Given this list of marker genes Hspa9, Leprotl1, Rbpj, Nkd1, Gm6878, Grm7, Nbl1, Krtap6-6, Gxylt1, Fermt1, Gid4, Ntng1 (netrin G1), Frat1, Zfp790, Hrh2 (histamine receptor H2), Kif3c, 1700028K03Rik, Taok1, Coq8b, Nr2c2, Trim46, Ezh2, Mapkbp1, Impdh1, Elk4, Tmem266, Natd1, Hmbox1, Atg13, Coro7, Ppm1l, Rb1, Smyd5, Cep350, Zdhhc20, Slc9a9, Dpy19l3, Celf4, Nfat5 (nuclear factor of activated T cells 5), Bltp3a, Gm16130, Camta1, Psma1, Srp14, Msantd3 (Myb/SANT-like DNA-binding domain containing 3), Pcnx2, Pgam1, Ephb2, Gbx2, Tmem178b, Kmt2a, Hs3st3a1, Mtif3, Itga5, Acot3, Ppargc1a, Esr1, Fam78a, Cavin1, Shisal2b, Zfp788, Snx27, Smg1, Sppl2b, Zeb2, Macrod2 (mono-ADP ribosylhydrolase 2), Slc8a2, Wdr47, Kpna3, Cuedc1, Cplx3, Bcl9, Anks1, Gabrg2, Ppp1r12a, Garem1, Zbtb14, Cnot6, Pgrmc2, Bicd2, Tmod1, Larp4b, Gpatch2l, Kcnq5, Cnga4, Acvr2b, Thtpa, Kmt2c, Nfya, Hipk3, Elovl5, Ubiad1, Fbxo11, Kcna6, Tbc1d16, Fat3, Fhip2b, Prx, Gab2, Erc1, Ubqln3 (ubiquilin 3), Tbl1xr1, Nexmif, Csde1, Mtf2, Cd22, Ctsb, Pacrg, Sox5, Gtpbp2, Zc3h6, Arhgef12, Slc39a12, Smurf2, Nup160, Qsox2, Csf1, Olfm1, Usp36, Ikzf2, Wdtc1, Tnpo1, Zmynd11, Ahi1, Plcb1, Mtf1, Clasp1, Ptpre, Srsf11, Creb5, Smg7, Amph, Dhrs9, Creld2 (NCBI Gene Id 97988), Jak1, Itgb8, Myo18a, Ndor1, Spsb1, Inpp5a, Snx2, Usf2, Tpd52l2, Ppp3ca, Tln2, Slc25a12, Arhgap18, Rdh8, Entrep3 (endosomal transmembrane epsin interactor 3), Necab1, here is a description of the gene set: species: Mus musculus Mouse Gene Set: MIR_1968_5P from publication Chen Y, Wang X (PMID 31504780) Genes predicted to be targets of miRBase v22 microRNA mmu_miR_1968_5p in miRDB v6.0 with MirTarget v4 prediction scores > 80 (high confidence targets).